The following is a description of a gene set: species: Mus musculus Mouse Gene Set: GOMF_LIGASE_ACTIVITY Catalysis of the joining of two molecules, or two groups within a single molecule, using the energy from the hydrolysis of ATP, a similar triphosphate, or a pH gradient., and this is the list of marker genes: Slc27a4, Hlcs, Hars1, Slc27a6, Uba3 (NCBI Gene Id 319310), Fpgs, Acsl1, Asnsd1, Wars1, Ttl, Aars1, Atp5pf, Gss, Itch, Lig1, Mocs3, Lig3, Ttll1, Yars2 (tyrosyl-tRNA synthetase 2 (mitochondrial)), Mccc2, Tars2, Qars1, Qrsl1, Adss1, Acaca, Dip2a, Gatb, Naprt, Asns, Acacb, Ppcs, Atp5mf, Cps1, Mid1ip1, Vars1, Rtca, Mthfs, Acsl6, Sars1, Ttll3, Ttll7, Rars1, Acsm1, Lgsn (NCBI Gene Id 266744), Aacs, Ttll13, Lars2, Mccc1, Nae1, Mthfsl, Farsa, Adss2, Tars1, Uba1y, Rtcb, Aarsd1 (NCBI Gene Id 69684), Atp6-ps, mt-Atp8, Slc27a1, Ghdc, Atp6v1a, Eprs1, Gclc, Yars1, Atp5mg, Pars2, Ttll4, Uba7, Pcx, Capn3, Atp5f1a, Slc27a2, Ctps2, Paics, Slc27a3, Atp5f1b, Ttll10, Gart, Dalrd3, Lipt2, Dars1, Aasdh, Acss3, Atp5pb, Ttll5, Acsl5, Kars1, Acsm3, Atp5pd, Sae1, Ass1, Iars1, Cars2, Ttll8, Atp5f1d, Atp5me, Carns1, Rars2, Rcl1, Acsf2, mt-Atp6 (NCBI Gene Id 98563), Ttll2, Acsf3, Acss2, Atp5f1c, Rimklb, Sucla2, Atp5po (ATP synthase peripheral stalk subunit OSCP, NCBI Gene Id 28080), Sars2, Acsbg2, Lig4, Nars2 (NCBI Gene Id 244141), Pfas, Gmps, Ctps1, Atp5f1e, Aars2, Atg5lrt, Gclm, Ttll9, Acsm5, Nars1, Pccb, Acsbg3, Mars1, Glul, Uba1, Rimkla, Mthfd1l, Acss1 (acyl-CoA synthetase short-chain family member 1), Acsm2, Acsl3, Gars1, Acsm4, Farsb, Tpgs1, Suclg1, Lars1, Uba2, Cars1, Ears2, Acsbg1, Fars2, Vars2, Tars3, Hars2, Trim25, Mthfd1, Dars2, Wars2 (NCBI Gene Id 99607), Ttll12, Iars2, Rlig1, Nadsyn1, Lrrc47, Acsl4 (NCBI Gene Id 50790), Gatc, Mars2, Mdm2, Dph6, Ttll11, Uba5, Atg7, Suclg2, Slc27a5, Pcca, Ttll6, Uba6, Cad